Given this list of marker genes Pde4d, Cnga1, Cnbd2, Hcn4, Prkar2b, Popdc2, Rapgef3, Hcn1, Rapgef2, Cnga4, Pde4a, Pde4b, Prkar1b, Bves, Cngb1, Pde2a, Popdc3, Prkar2a, Cnga2, Hcn3, Pde10a, Hcn2, Rapgef4, Pde1c, Prkar1a (NCBI Gene Id 80472), here is a description of the gene set: studied in species Mus musculus Binding to cAMP, the nucleotide cyclic AMP (adenosine 3',5'-cyclophosphate). Mouse Gene Set: GOMF_CAMP_BINDING